The following is a description of a gene set: studied in species Mus musculus The series of molecular signals initiated by the cross-linking of an antigen receptor on a B cell. Mouse Gene Set: GOBP_B_CELL_RECEPTOR_SIGNALING_PATHWAY, and this is the list of marker genes: Btk, Nfkb1, Foxp1, Rftn1, Bax, Ms4a1, Plcl2, Slc39a10, Mapk1, Lck, Blk, Cd79b, Plcg2, Nfkbiz, Stap1, Ighe, Blnk, Lpxn, Prkcb, Prkch, Cd22, Ptprc, Itk, Ptpn6, Klhl6, Cd38, Vav3, Sh2b2, Syk, Lime1, Bcl2, Nfam1, Lyn, Bmx, Tec, Gps2, Nckap1l, Cd79a, Mef2c, Plekha1, Cd300a, Grb2, Gcsam, Cd19, Cmtm3, Lat2, Sos1, Ctla4, Abl1, Fcrl5, Bcar1, Nfkbia, Fcmr, Cd81, Nfatc2, Ighm